The following is a description of a gene set: species: Mus musculus Mouse Gene Set: chr5C2, and this is the list of marker genes: 1700014F14Rik, Gm8182, Gm43044, Gm42861, Cbfa2t2-ps1, Gm3372, Gm6632, Gm23331, Gm23708, 4933402J10Rik